Given this list of marker genes Gbe1, Slc37a1, Pgam2, Galns, Rbks, Hexa, Chst12, Taldo1, Hs6st2, Man2b2, Galk1, G6pc2, Eno3, Hs3st4, Glb1l2, Nup205, Gpc2, Hyal4, Ndst3, Xylt2, Chst9, Csgalnact1, Khk (ketohexokinase), Galm, Hpse2, Aldob, Pgm2, St3gal2, St3gal4 (ST3 beta-galactoside alpha-2,3-sialyltransferase 4), Kera, Omd, Sgsh, Nup210, Pygm, Hmmr (hyaluronan mediated motility receptor (RHAMM)), Ids, Chst15, B3galt4, Chst2, B4galt6, Ugp2, Shpk, Hkdc1, Nup133, B3galt5, Hyal5, Slc26a1, Pgm2l1, Chsy3, B3gnt3, Gnpda1, Cspg5, Pck2, Bgn, Ndst2, Slc35d2, Hk2, G6pc1, Hyal1, Rae1, Gapdhs, Man2c1, St3gal3, G6pc3, Akr1b1, Ust, Glb1l, Slc2a1, Eno4, Nup93, Fbp2 (NCBI Gene Id 14120), Hs3st2, Phkg2, Lum, Pfkl, Tpi1, Abo, Nup85, Slc9a1, B3gat3, Sdc3, Fut4, Hs3st3b1, B3galt2, Tkfc, G6pdx, Chst14, Hyal2, B3gat1 (NCBI Gene Id 76898), Gpc3, B3gat2, Aaas, Sdc1, Calm1, B4galnt2, Chsy1, Man2b1, Hs6st3, Hexb (NCBI Gene Id 15212), B4galt7, Dsel, Pfkfb1, St6galnac6, Slc26a2, Gckr, Glb1l3, Nup54, Fut9, Chst13, Csgalnact2, Slc37a4, Nup42, Rpia, Hk3, Fut2, Hs6st1, Pgls, Has1, Glyctk, Slc26a11, Aldoa (aldolase A, fructose-bisphosphate), Galt, Xylt1, Dse, Tkt, Seh1l, Nup58, Gale, Ext1, Pkm, Acan, Naglu, Slc35b2, Ndc1, Pgk2, B3galt6, Dcn, Fut1, Nup155, Chst5, Lalba, Slc37a2, Stab2, here is a description of the gene set: studied in species Mus musculus This event has been computationally inferred from an event that has been demonstrated in another species.<p>The inference is based on the homology mapping from PANTHER. Briefly, reactions for which all involved PhysicalEntities (in input, output and catalyst) have a mapped orthologue/paralogue (for complexes at least 75% of components must have a mapping) are inferred to the other species. part of: Metabolism electronically inferred by orthology from the curated human pathway Reactome Pathway: Metabolism of carbohydrates and carbohydrate derivatives